Given this list of marker genes Smtn, Crh, Ier3, Tac1, Nppb, Prcp, Kl, Tac4, Adrb1, Ntsr1, Adra1a, Tnf (tumor necrosis factor), Mrgprd, Calca, Mas1, Trpv1, Apln, Adrb2, Agt, Ahr, Adora1, Adra1d, Kdr, Arhgap42, Bbs4, Bmpr2, Gpr37l1, Agtr2, Kcnk6, G6pdx, Sod2, Nppa (NCBI Gene Id 230899), Nedd4l, Adrb3, here is a description of the gene set: studied in species Mus musculus The process that reduces the force with which blood travels through the systemic arterial circulatory system. Mouse Gene Set: GOBP_NEGATIVE_REGULATION_OF_SYSTEMIC_ARTERIAL_BLOOD_PRESSURE